Given this list of marker genes EPB41L2, GTF2A2, ST13, NCAPD2, SLC39A14, TRIM46, ESD, DPT, BLTP3B, KIF11, SYMPK, ZDHHC14, COPS3, SGCG, NDC1, C1QBP, TNFRSF8, RFC4, VDAC2, SSBP1, RTRAF, RTCB, GUF1, AKAP12, GMEB1, H2AZ1, TDP1, GPR171, FRG1, GAN, CDC25A, FRMD4B, NDUFB3, NCBP1, FDFT1 (NCBI Gene Id 2222), NASP, HEMK1, CCT6A, PCK2, POMP, RRM1, RRM2, GINS4, TBC1D4, MCM5, SEC61B, SFXN1, PPAT, EZR, SNRPE, CD40LG, FANCI, KIF18B (kinesin family member 18B), TIPIN, RAD51, BAG2, NOL3, ATP5F1B, H4C9, TGIF2, BIRC5, PTTG1, PSMB5, MACROH2A1, LUC7L2, FILIP1L, BUB3, CKAP2, XRCC3, CDC123, MIS18BP1, GINS2, UBE2N, LRRN3, PPP2CA, PCNA, CXCR6, CCT7, DAP3, ATP5F1A, LRRC8B, MYH6, NCAPG, PIP5K1B, EPAS1, KIF2C, ABCG2, TNS3, OSM, MANF, PAK1IP1 (NCBI Gene Id 55003), LONP1, COQ3, ESPL1, JADE3, TRAC, PNO1, PRPS2, GGCT, RAD54L, LBHD1, E2F3, C2orf49, EHD4, TSPAN13, PDE12, POLA2, MDM2, HSPE1, PRDX3, ICOS, ZNF613, CLPB, KIF20A, INTS6, LAGE3, AKIP1, EMSY, HNRNPK, IRGQ (immunity related GTPase Q), SNRPD3, SIAH2, RAB33A, ABCE1, HEATR1, CDK7, CKS1B (NCBI Gene Id 88475), DUSP4 (dual specificity phosphatase 4), SLAMF1, MRPL15, DTL, NMD3, FIRRM, POLE2, TMEM70 (NCBI Gene Id 54968), HIVEP3, ATAD2, KIF20B, CCNA2, CFAP298, PLA2G4A, MSH2, TYMS, CKS2, MRPL58, PRR3, GRAMD1B, SLCO4A1, SNRPG, NUDT21, ICAM1, TSFM, ACOT7, UTP20, RPP25, NUSAP1, LRFN4, DCLRE1A, RBBP8, RSL1D1, MRPL3, RALB, CENPI, PSMB6, INPP4B, TSKU, RPUSD2, SIRPG, CCNB2, NFE2L3, SLC7A5, GMNN, PHYH, CLIC4, TSN, SMC2, RPL26L1, SRSF1, SCD (stearoyl-CoA desaturase), CLNS1A, CD200, AURKA, RETREG1, TMEM106C, CNOT7, PTGS2, CENPA, TFDP1, GLUD1, COA7, PSMC5, LDHB, STIL, KIF18A, HK2 (NCBI Gene Id 3099), PDCD5 (NCBI Gene Id 9141), HMGB3P1, PGAP1, NCAPG2, CFI, here is a description of the gene set: Genes down-regulated in comparison of NK cells versus Th2 cells. In the present study we used Affymetrix oligonucleotide microarrays to produce gene transcription profiles for the major leukocyte types in humans. This comprehensive dataset enabled us to not only establish which genes were expressed in each leukocyte type, but also which genes were expressed in each subset after activation. The used of a comprehensive dataset of gene profiles from all the major human leukocyte subsets enabled a novel and powerful means for identification of genes associated with single leukocyte subsets, or different immune paradigms. Human Gene Set: GSE3982_NKCELL_VS_TH2_DN species: Homo sapiens from publication Jeffrey KL, Brummer T, Rolph MS, Liu SM, Callejas NA, Grumont RJ, Gillieron C, Mackay F, Grey S, Camps M, Rommel C, Gerondakis SD, Mackay CR (PMID 16474395)